The following is a description of a gene set: Human Gene Set: HP_SMALL_INTESTINAL_STENOSIS studied in species Homo sapiens Small intestinal stenosis The narrowing or partial blockage of a portion of the small intestine., and this is the list of marker genes: RAD51 (NCBI Gene Id 5888), TTC7A, BRCA1, FANCB, RARB, RAD51C, FANCM, FANCE, FOXF1, BRCA2, FANCF, UBE2T, FANCD2, WNT7B, FANCL, FANCG, PALB2, STRA6, FANCI, FANCC, XRCC2, RFWD3, BRIP1, MAD2L2, CDC45, ERCC4, SMAD4, SLX4, FANCA